The following is a description of a gene set: Catalysis of the reaction: an N-acyl-L-alpha-aminoacyl-tRNA + H2O = an N-acyl-L-amino acid + a tRNA + H+. studied in species Homo sapiens Human Gene Set: GOMF_PEPTIDYL_TRNA_HYDROLASE_ACTIVITY, and this is the list of marker genes: ETF1, PTRHD1, MRPL58, PTRH1, PTRH2